The following is a description of a gene set: Human Gene Set: GOBP_ADAPTIVE_THERMOGENESIS The regulated production of heat in response to short term environmental changes, such as stress, diet or reduced temperature. species: Homo sapiens, and this is the list of marker genes: OXT, GNAS, PPARGC1B, CCR2, FLCN, SORL1, NOVA2, GPR3, FH, APPL2, PWWP2B, ADCYAP1, ELOVL6, TRPM8, PRLR, SLC25A5, PRDM16, LETMD1, ADAM17, CKB, PRKAB1, STAT6, IGF1R, NR1H3, PGAM5, VEGFA, PPARGC1A, KDM3A, YBX2, MFAP2, UCP3, IGF2BP2, FABP4, DDIT3, ACOT11, PLCL2 (NCBI Gene Id 23228), SYK, NRDC, GJA1, PHOX2B, PCTP, WNT10B, OMA1, LEP, GRB10, ACHE, GHRL, ACTN3, FFAR4, IRF4, ZNF516, ZNF423, ACVR2B, IL18R1, ID1, ZBTB7B, SIRT6, ALPL, BOLA3, LPIN1, IP6K1, LGR4, ALDH1A1, IL18, RHEB, APC, GADD45G, LEPR, ESRRG, SCD, DIO2, ACOT13, KDM1A, HNRNPU, NR1D1 (NCBI Gene Id 9572), IL13, PRKAB2, ADRB2, TLE3, UCP1, NOVA1, JAK2, ATF4, HADH, ADRB3, BMP8A, CPT2, LIPA, ADRB1 (adrenoceptor beta 1), STK11, HOXC10, ARRDC3, NPR3, IL4, EHMT1, SCT, ADISSP, DECR1, TFE3, LNPEP, TRPV2, IL4R (interleukin 4 receptor), TLR4, ACADL, ABHD6, RB1, ELOVL3, SFXN5, DYNC1H1, CEBPB, DBH, CNOT3, PLAC8, NOTCH1, PLCL1, LAMA4, FOXC2 (forkhead box C2), PTH2R, CLSTN3, MFN2, MAP2K6, SLC25A4, SLC25A44, SCTR, OGT, ADIPOR1, G0S2, CAV1, S100B, ADAMTS5, ADIPOR2, PER2, HDAC3, NR1H2, KDM6B, UCP2, TRPV1, GATM, PDGFC, KSR2, CMKLR1, IL15, LCN2, ALMS1, ADIPOQ, BMAL1, ACSL1, RBPJ, SMARCA4, OXTR, THADA, TSHR, BSCL2, CXCR4, SLN, DOCK7 (NCBI Gene Id 85440), CIDEA, TRPV4, CD36, FGF21, EPAS1, THRA, HCRT, FABP5, PM20D1, HSF1, PEMT, QKI, EBF2